The following is a description of a gene set: Human Gene Set: GOBP_PEPTIDYL_THREONINE_PHOSPHORYLATION The phosphorylation of peptidyl-threonine to form peptidyl-O-phospho-L-threonine. studied in species Homo sapiens, and this is the list of marker genes: ATF2, PARD3, CSNK2B, CHI3L1, AKT1, STOX1, UBE2K (NCBI Gene Id 84819), TRIM6, NLK, TBK1, LMTK2, CEMIP, CADM4, MAPK8, TNKS, CDK10, EGF, IRGM, MAP3K10, WNK3, MAPK1 (NCBI Gene Id 5594), HIPK3, SIRT2, PRKCA, CDK5R1, STK11, PRKD1, PRKDC, S1PR2, CDK1, SPHK1, ACVR1B, STK39 (serine/threonine kinase 39), CAMK2A, CHEK1, PRKD2, TTBK1, DMTN, MYLK2 (NCBI Gene Id 85366), PRKCD